Given this list of marker genes TREX1, POLG, RRM2B, ADNP, PDP1, POLG2, TWNK, TSC2, MTRFR, TSC1, ZEB2 (NCBI Gene Id 9839), MTOR (NCBI Gene Id 2476), SLC25A4, RNASET2, PIK3C2A, here is a description of the gene set: Focal white matter lesions Human Gene Set: HP_FOCAL_WHITE_MATTER_LESIONS studied in species Homo sapiens